Given this list of marker genes IDH1, ME1, ATF4, PALB2, PRKCD, UBA52, PDGFA, CDKN1A, PSMA2, NFE2L2, EP300, CUL3, AKT1, TKT, PSMB2, TALDO1, NPLOC4, PSMB1, PSMC4, PRKAA2, PSMA4 (NCBI Gene Id 5685), ABCC1, PSMD12, ABCG2, PSMA6, TXN, PSMA3, HMOX1, BACH1 (NCBI Gene Id 571), NQO1, VCP, EGF, GSK3B, AREG, PGD, CCL2, CSNK2A1, UBXN7, GSR, CREBBP, DPP3, CDKN2A, BRCA1, PSMD13, SQSTM1, RPS27A, PSMD6, PSMB7, GCLM, PSMC6, TXNRD1, PSMD8, PRDX1, SLC7A11, PRKCI, PSMA5, PSMA7, AKT2, PSMB3, BCL2, UBB, MUL1, SKP1, NFKB1, PSMD1, MYC, PSMC2 (proteasome 26S subunit, ATPase 2), SKP2, PSMD11, MAFG, BCL2L1, NOTCH1, MAP1LC3B, ADRM1 (NCBI Gene Id 11047), ABCC3, KEAP1, PSMD14, AMER1 (NCBI Gene Id 160176), PSMC3, TRIM21, SESN2, FBXL17, PSMA1, UFD1, CSNK2B, GCLC (glutamate-cysteine ligase catalytic subunit), GSTA1, SOD3, PSMD2, SRXN1, RBX1, PSMD3, CSNK2A2, ABCF2, PSMC5, UBC, PSMB6, PSMB5, GSTA3, EIF2AK3, MAFK, PSMB4, SESN1, CUL1, PSMD7, RELA, SEM1, PSMC1, AKT3, BTRC, SP1, G6PD (NCBI Gene Id 83159), here is a description of the gene set: KEAP1-NFE2L2 pathway Human Gene Set: REACTOME_KEAP1_NFE2L2_PATHWAY studied in species Homo sapiens